The following is a description of a gene set: studied in species Homo sapiens Genes related to PIP3 signaling in B lymphocytes Human Gene Set: SIG_PIP3_SIGNALING_IN_B_LYMPHOCYTES, and this is the list of marker genes: AKT2, SAG, FLOT1, FLOT2, PIK3R5, CYTH3 (cytohesin 3), CD19, AKT3, FOXO3, PPP1R13B, PTEN, VAV1, LYN, SYK, DAPP1 (dual adaptor of phosphotyrosine and 3-phosphoinositides 1), NR0B2, RPS6KA1, TEC, PTPRC, PREX1, RPS6KA2, ITPR1, CDKN2A, PLCG2, AKT1, PDPK1 (3-phosphoinositide dependent protein kinase 1), PIK3CA, ITPR2, PITX2, ITPR3, BCR, RPS6KB1, GAB1, BTK, PHF11, RPS6KA3